The following is a description of a gene set: Human Gene Set: GOMF_DOPAMINE_NEUROTRANSMITTER_RECEPTOR_ACTIVITY studied in species Homo sapiens Combining with the neurotransmitter dopamine to initiate a change in cell activity., and this is the list of marker genes: DRD1, DRD5, DRD4, DRD2, DRD3